Given this list of marker genes CEP57, GLCE, PAIP2, TRIM23, MYOCD, CLUH (clustered mitochondria homolog), PTPRC, SLC8A1, ZNF22, HSPD1, GRIA4, PHF6, CSTA, RMDN1, SNX2 (NCBI Gene Id 6643), DOK6, SCLT1, GATM, STXBP6, SVIP, NCAM1, TPX2, ZNF180, BAZ2A, NUDT19, TRDN, SOD2, SUPT3H, RND1, PDE11A, SELENOK, JMJD1C, ZNF800, GRIK4, SLC45A2, KDM5C, PATE4, TBX21, LRP2BP, DNHD1, RPTN, RNF11, AKAP11 (NCBI Gene Id 79988), JARID2, ZNF302, INTS6, LIAT1, BRDT, SOSTDC1, KAT6B, ABI1, MTMR12, ANO2, TKTL1, SSR3, PPP1CB, PPP2R5E, WDR82, STX16, TENT5D, PDE7B, HSF2BP, PRPF38B, here is a description of the gene set: Genes predicted to be targets of miRBase v22 microRNA hsa-miR-8069 in miRDB v6.0 with MirTarget v4 prediction scores > 80 (high confidence targets). from publication Chen Y, Wang X (PMID 31504780) species: Homo sapiens Human Gene Set: MIR8069